The following is a description of a gene set: species: Mus musculus Mouse Gene Set: GOMF_OXALATE_TRANSMEMBRANE_TRANSPORTER_ACTIVITY Enables the transfer of oxalate from one side of a membrane to the other. Oxalate, or ethanedioic acid, occurs in many plants and is highly toxic to animals., and this is the list of marker genes: Slc26a8, Slc26a6, Slc26a9, Slc26a5, Slc26a7, Slc26a1, Slc26a10, Slc26a4, Slc26a2, Slc26a3